The following is a description of a gene set: Mouse Gene Set: MIR_1271_3P from publication Chen Y, Wang X (PMID 31504780) species: Mus musculus Genes predicted to be targets of miRBase v22 microRNA mmu_miR_1271_3p in miRDB v6.0 with MirTarget v4 prediction scores > 80 (high confidence targets)., and this is the list of marker genes: Phactr2 (NCBI Gene Id 215789), Cln5, Fchsd2, B3gat3, Fat2, Ttc21b, Nedd4, Lrrc75a, Kbtbd4, Onecut3, Zfp704, Cdkn1b, Rnf157, Npas2, Capzb, Dock4, Cacna1d, Smad4, Trnt1, Yipf6, Slc36a4, Abi1, Spock1, Stk33, Ptprg, Nek7, Brd1, Tyw3, Adcyap1, Atm, Khdc4, Gypc, Luc7l3, Dcun1d3, Etl4, Sucla2, Cpeb4, Tmem207, Fbxo42, Dcaf5, Zc2hc1a, Nr4a2, Cbll1